Given this list of marker genes Mtor, Gpbar1, Hdac6, Pkhd1, Lims1, Nppb, Lims2, Cdc25a, here is a description of the gene set: Any process that modulates the frequency, rate or extent of cholangiocyte proliferation. species: Mus musculus Mouse Gene Set: GOBP_REGULATION_OF_CHOLANGIOCYTE_PROLIFERATION